The following is a description of a gene set: from publication Kaji T, Ishige A, Hikida M, Taka J, Hijikata A, Kubo M, Nagashima T, Takahashi Y, Kurosaki T, Okada M, Ohara O, Rajewsky K, Takemori T (PMID 23027924) To obtain insight into the genetic basis of the increase of functional activity of memory B cells over time, we compared the gene expression profiles of day 7 and day 40 NP-specific/IgG1 memory B cells, GC B cells and plasma cells in immunized WT mice and naïve B cells, before and after activation in vitro. studied in species Homo sapiens Genes up-regulated in follicular B cells versus day 40 memory B cells. Human Gene Set: GSE11961_FOLLICULAR_BCELL_VS_MEMORY_BCELL_DAY40_UP, and this is the list of marker genes: NFATC2, SLC30A4, DYNLT2B, TMEM176B, PLCG2, PARVG, CD8B, CIMIP6, SAXO1, DLX2, BCAT2, ZMYM3, HSD17B12 (NCBI Gene Id 51144), RPL28, CCDC120, GLRX, MAP3K12, PARP8, DDHD1, ERO1B, SNX2, PTTG1IP, NOBOX, SH3BGRL, MLH3, DOCK7, SAA1, ADGRA3, FLVCR1, JARID2, GSTO1, CRYZ, SLC4A9, MLEC, KCNE5, RALB (NCBI Gene Id 5899), LYST, SUMF1, NTN3, ARRDC4, ERP29, INSIG1, OXCT1, TSG101, HCN3, CYB5A, PAN3, DOK4, FAM241A, ATP6V0A2, PI4K2A, OAT, PPHLN1, SLC25A23, TBC1D22A, PIWIL2, DTNB, IDH2, GPI (NCBI Gene Id 2821), PES1, GRAMD2B, HMOX2, TNS1, PRKRA, COPZ2 (NCBI Gene Id 51226), CCDC183, SRMS, STK32A, HAVCR1, RNF19B, WNT10B, KLHL35, GPR35, EVA1C, HS6ST3, NDUFA9, GOT2, MOCOS, INTS4, UROS, EIF2B2, SLC10A6, POLR1H, DNAL1, ELL3, NAIF1, CYB561A3 (cytochrome b561 family member A3), PTPRO, PLA2G12B, PGS1, PHKA2 (phosphorylase kinase regulatory subunit alpha 2), GMPPB, ISCU, PLIN3, TBC1D9, DAGLB, MYOF, MFSD1, CACNA1S, WNT6, TNFRSF11A, SOD3, BOK, CFAP69, WIPI1, MORN1 (NCBI Gene Id 79906), SLC7A5, MRPL11, UBE2F, RGS7BP, ABCA5, NR0B2, FDFT1, HMGCR, IFT22, ALG8, TBC1D31, ZDHHC2, DEPTOR, SPATA31F1, PRLR, PHYHIP, LRFN3, ARHGEF10, TRIO, DHRS1, CD27-AS1, SGSM3, ZNF629, TSSK2, HLCS, MAP3K14, LDLRAD3, LAP3, TMEM79, NOSTRIN, NFASC, GYS1, CCKBR, OLFM1, AARS1, MYBPC3, NEDD4, IRGM, C11orf24, GRIN1, GARS1, ARMCX6, FAM162B, CDX4, MYO1H, BDH1, SNX9, PLXND1, CCNB1IP1, CFP, WDR86, RALA, POMP, RTN1, HIF1A, TMPO, GMPR2, BCO2, GALC, AKAP7, IL17RC, ALS2, LMO1, TEFM, NPR1, SLC26A8, FAM216A, PPP1R36, CEP290, LKAAEAR1, SLC13A2, EXT1, UQCRC2, BTBD3, WASHC4, APIP, TNFRSF21, PLCG1, MFSD12, KIFAP3, KRT80, SSTR4, HOXA7, CLEC1A, COPS7A, CA9 (NCBI Gene Id 768), NUBPL, SLC22A5, TXNDC16, SENP8, XPNPEP1 (X-prolyl aminopeptidase 1), TRIP6, UNC93B1, NEURL1B